Given this list of marker genes TMEM107, GORAB, PRR12, BEST1, RAB3GAP2, RAI1 (retinoic acid induced 1), CRPPA (CDP-L-ribitol pyrophosphorylase A), GJA8, RSPO2, CC2D2A (coiled-coil and C2 domain containing 2A), BRD4, TMEM231, HMX1, FKTN, TMEM216, DAG1, KRAS, UBE3B (NCBI Gene Id 89910, ubiquitin protein ligase E3B), MED25, CHN1, GTF2E2, ERCC2, POMT2, CRYBA4, SALL4, LARGE1, EBP, RBP4 (retinol binding protein 4), B3GLCT, POMGNT2, TXNDC15 (NCBI Gene Id 79770), WNT3, MAFB, PAX6, TCTN3 (NCBI Gene Id 26123), CRYBB2, B3GALT6, JAG1, BMP4, ZEB2, ACTB, MAPRE2, RAB23, MITF, SMC3, HMGB3, DPYD, MKS1, CSPP1, IQSEC2, ARL2, PXDN, ERCC6, BCOR, CRYAA, HSPG2, NIPBL, FGF3, TBL1XR1, CRYBB1, B9D2 (NCBI Gene Id 80776), NDP, FANCB, MPLKIP, FLI1, ACTG1, TENM3, MAB21L2, FOXE3, KIF11, FKRP, CTDP1, ANK1, LMX1B, SC5D (sterol-C5-desaturase), NHS, RECQL4, POMK, B9D1, POMT1, GJA1, COL4A1, ERCC8, PLOD1, RPGRIP1, POMGNT1, TBX15, TMEM67, CEP290, ATOH7, RAD21, TARS1 (NCBI Gene Id 94887), AARS1, FZD4, RPGRIP1L, TFAP2A, TAF6, CRYGD, NAA10, TUBB, TBX22, PLK4, ADAMTS18, CTCF, PITX2, FKBP14, SLC16A12, DEAF1, SMC1A, FLII, KDM6A, PYCR1, CRYGC, ERCC3, CARS1, PRSS56, TBC1D20, OTX2, B3GALNT2, CHST14, CENPF, FOXL2, GTF2H5, RXYLT1, PITX3 (NCBI Gene Id 5309), TCTN1, RNF113A, MIR184, RAB3GAP1, MAF, HDAC8, TMEM237, B4GAT1, TCTN2, TBX4, RAB18, KMT2D, here is a description of the gene set: studied in species Homo sapiens A congenital abnormality of the cornea in which the cornea and the anterior segment of the eye are smaller than normal. The horizontal diameter of the cornea does not reach 10 mm even in adulthood. Microcornea Human Gene Set: HP_MICROCORNEA